The following is a description of a gene set: studied in species Homo sapiens Any process that activates or increases the frequency, rate or extent of mitotic cell cycle phase transition. Human Gene Set: GOBP_POSITIVE_REGULATION_OF_MITOTIC_CELL_CYCLE_PHASE_TRANSITION, and this is the list of marker genes: RAB11A, SKA1, PLRG1, BRD4, SIN3A, CCNE1, KLHL18, RGCC, CDC20, STOX1, RB1, FBXO5, MAD1L1, RRM2, CDC25B, CPSF3, RRM1 (ribonucleotide reductase catalytic subunit M1), CDC23, ANXA1, KMT2E, MBLAC1, SKA3, ESPL1, CDC16, MIR214, CDC7, FGF10, RAD51B, LSM10, PBX1, MAD2L1BP, CUL4A, DLGAP5, MIR520A, MIR221, CCNE2, RRM2B, MIR208A, CCND2, DDR2, NEUROG1, MDM2, MIR519D, UBE2E2, MIR520H, MIR372, WNT10B, PRAP1, CENPJ, ANAPC5, CDC6, CDC25C, CDK4, AIF1 (allograft inflammatory factor 1), CCNB1, TFDP1, ANAPC11, CDK10, UBE2C, EGFR, ADAM17, AKT1, KCNA5, MIR515-1, NSMCE2, RCC2, ADAMTS1, MTBP, CUL4B, VPS4B, MIR495, PHOX2B, ANKRD17, HSPA2, CYP1A1, MIR222, CUL3, TGFB1, STIL, DBF4B, LSM11, TERT, SMARCD3, CCND3, PLCB1, CCND1, MIR29A, MTA3, CDK1, DTL, CDC25A, RDX, CDCA5, DDX3X, SASS6, ANAPC7, BIRC5, RAD51C, PTENP1-AS, TMOD3, EIF4G1, MEPCE, RPTOR